The following is a description of a gene set: Signaling by ERBB2 can be pharmacologically inhibited with tyrosine kinase inhibitors (TKIs), and therapeutic antibodies, such as trastuzumab and pertuzumab. studied in species Homo sapiens Reactome Pathway: Drug-mediated inhibition of ERBB2 signaling part of: Signaling by ERBB2, and this is the list of marker genes: ERBB2, HSP90AA1, ERBIN, CDC37